Given this list of marker genes SMAD4, MTA1, CHD4, HDAC1, RBBP4, UCP1, PPARA, GATAD2B, PRDM16, MBD3, EBF2, NCOA1, HNRNPU, PPARGC1B, DIO2, COX7A1, CIDEA, MTA3, GATAD2A, PPARG, SMAD1, CHD3, BMP7, HDAC2, ELOVL3, USP46, RXRA, PPARGC1A, MTA2, RBBP7, ZNF423, here is a description of the gene set: studied in species Homo sapiens Human Gene Set: REACTOME_TRANSCRIPTIONAL_REGULATION_OF_BROWN_AND_BEIGE_ADIPOCYTE_DIFFERENTIATION Transcriptional regulation of brown and beige adipocyte differentiation